The following is a description of a gene set: Genes positively differentially expressed in cell type: Neutrophil upon treatment with cytokine: IL-15 in mouse lymph nodes in vivo. Cytokines mediate cell-cell communication in the immune system and represent important therapeutic targets. A myriad of studies have highlighted their central role in immune function, yet we lack a global view of the cellular responses of each immune cell type to each cytokine. To address this gap, the authors created the Immune Dictionary, a compendium of single-cell transcriptomic profiles of more than 17 immune cell types in response to each of 86 cytokines (>1,400 cytokine-cell type combinations) in mouse lymph nodes in vivo. A cytokine-centric view of the dictionary revealed that most cytokines induce highly cell-type-specific responses. For example, the inflammatory cytokine interleukin-1β induces distinct gene programmes in almost every cell type. A cell-type-centric view of the dictionary identified more than 66 cytokine-driven cellular polarization states across immune cell types, including previously uncharacterized states such as an interleukin-18-induced polyfunctional natural killer cell state. studied in species Mus musculus Mouse Gene Set: CUI_NEUTROPHIL_IL15_RESPONSE_UP from publication Cui A, Huang T, Li S, Ma A, Pérez JL, Sander C, Keskin DB, Wu CJ, Fraenkel E, Hacohen N (PMID 38057668), and this is the list of marker genes: Acod1, Oas3, Slfn4, Casp4, Cd274, Samhd1, Clec2d, Gbp5, Daxx, Fcgr4, Cxcl10, Herc6, Ifi204 (interferon activated gene 204), Parp14, Tagap, Tnfaip2, Stat1, Oasl2, Irf1, Gbp2, Ifi47, Tap1, Ifit3, Psmb8, Gbp7, Igtp, Pnp, Sod2, Ifitm3, Zup1, Irgm1, Ifit3b, Trafd1, Ifit2, H2-D1, Socs1, Ifit1